The following is a description of a gene set: from publication Chen Y, Wang X (PMID 31504780) Human Gene Set: MIR4658 Genes predicted to be targets of miRBase v22 microRNA hsa-miR-4658 in miRDB v6.0 with MirTarget v4 prediction scores > 80 (high confidence targets). species: Homo sapiens, and this is the list of marker genes: SLC2A2, ERICH3, COL15A1, CDC14A, IDH1, RIMKLA, CPM, ARPP21, STK39, NRN1, LYPLAL1, RASSF9, PLXNA4 (NCBI Gene Id 91584), APELA, SOAT1, PRELID1, OLA1, PRKCQ, NSD1, SLC35F4, ZNF772, PTHLH, APOBEC3D, WLS, LRPPRC, INS-IGF2, NLGN4Y, TASOR2, RSRP1, SERPINA5, KALRN, ZCCHC2, TCF20, PDE1A, GDAP2, GOLGA1, CNMD, LONRF1, ARID5B, PHF20L1, KLHL11, UBA3, FOXI2, GDF6, EHHADH, HADH, MALT1